The following is a description of a gene set: Telangiectases (small dilated blood vessels) located near the surface of the skin of the face. studied in species Homo sapiens Human Gene Set: HP_FACIAL_TELANGIECTASIA Facial telangiectasia, and this is the list of marker genes: ATRX, ACVRL1, ARX, CAST, TTI1, SOX18, VPS53, ATR, SLC2A10, SLC29A3, POLE, WNT10A, GNPTAB, SDHD, ARPC4, BLM